Given this list of marker genes Mst1r, Cript, Gm266, Rassf4, Ythdf2, Pou3f2, Sox15, Fam169a, Zfp93, Zfp64 (zinc finger protein 64), Smim19, Pde8b, here is a description of the gene set: Mouse Gene Set: MIR_3083_3P Genes predicted to be targets of miRBase v22 microRNA mmu_miR_3083_3p in miRDB v6.0 with MirTarget v4 prediction scores > 80 (high confidence targets). studied in species Mus musculus from publication Chen Y, Wang X (PMID 31504780)